Given this list of marker genes MYBPC1, MAP10, MAGI2, NDRG3 (NCBI Gene Id 64401), C2CD5, TMEM14C, TMEM263, SSMEM1, AGTRAP, AP4B1, PRKX, SQLE, AHCYL1, COPS4, NAA38, CPLANE1, MICU1, LYPD6, C5orf63, MINDY3, COX7A1, UNC5CL, C1orf141, CENPA, GAS2, FZR1, N6AMT1, ERLIN2, NAGK (N-acetylglucosamine kinase), FBF1, TUBB2B, TMEM127, SERPINA4, LYRM9, USP33, PCDH7, VPS13C (vacuolar protein sorting 13 homolog C), HS3ST6, NUP62, NOXO1, DNAJB1, GMFB, ZNF8, GNG7, TRIP4, ATP6V1C2, SOCS4, WRNIP1, ADH4, PLA2G10, NAT9, ATRN, RB1, ORAI3, NUP50, KRTAP11-1, CENPK (centromere protein K), CCDC183, FGF2, NEK3, FGD5, BRI3, CHD6, PRDM8, GALK1, TMED5, RNF145, YPEL1, ZNF777, EFCAB6, LRRC3B, TRAPPC6B, TBC1D22A, SEMA3C, TMEM269, OGFOD2, FIBP (NCBI Gene Id 9158), TNS1, REC114, TLNRD1, FITM2, WASHC1, HOXA13, METTL14, DCPS, PRKAG2, THG1L, TMEM43, ALDH18A1, TUBA1A, FBXO4, SENP8, LZTS2, ALG10, DCUN1D4, WDTC1, IGDCC4, EPHX4, KDELR3, ELFN2, MARCHF3, HTRA1, ISLR, ABAT, KCNH5, FOXQ1, PHF20, DUS3L, FAM228A, KNOP1, SLC25A15, FXR2, GSS, ZBTB42, CYB561D1, LAMTOR5, B3GALNT1, RAB25, CTTNBP2, QSOX1, TFPT, OCSTAMP, BRD10 (NCBI Gene Id 158358), ATXN1L, SPCS2, TST, SRR, SH2D4B, SIPA1L3, N4BP2, PLEKHM1, SUFU, ZNHIT3, IRGQ, ZRANB3, RHBDD2, HMBOX1, TP53I11, HOXB2, LEAP2, MICAL2, PAFAH2, AQP9, TCEANC2, ASS1, SECTM1, SLC6A13, SGTB, H6PD, PGAM5, FAM151A, SLC35F6, ACOT11 (NCBI Gene Id 91515), TRMT12 (NCBI Gene Id 55039), THOP1, SYCP2L, FAM89A, MED16, DDX39B, MAPDA, HECTD3, RAB11FIP2, ACER3, RRAGC, CXXC5, HMGN5, IGFBP6, NCAPG2 (non-SMC condensin II complex subunit G2), RNF40, DENND2C (NCBI Gene Id 163259), SLITRK4, KMO, HINT3, HTRA4, PACS2, RAD17, UBA6, ABHD15, CXCL14, CA9, PDE2A, LIPA, TMEM116, ZNF112, NKAPL, PHLDA3, KLHL22, STK40, CHST10, RAD52, APEX2 (NCBI Gene Id 27301), SLCO4C1, GK, MRPS24, ICE1, CABYR, MPDZ, PPM1F, TMEM181, here is a description of the gene set: Human Gene Set: GSE11961_PLASMA_CELL_DAY7_VS_GERMINAL_CENTER_BCELL_DAY40_DN To obtain insight into the genetic basis of the increase of functional activity of memory B cells over time, we compared the gene expression profiles of day 7 and day 40 NP-specific/IgG1 memory B cells, GC B cells and plasma cells in immunized WT mice and naïve B cells, before and after activation in vitro. Genes down-regulated in day 7 plasma cells versus day 40 germinal center B cells. species: Homo sapiens from publication Kaji T, Ishige A, Hikida M, Taka J, Hijikata A, Kubo M, Nagashima T, Takahashi Y, Kurosaki T, Okada M, Ohara O, Rajewsky K, Takemori T (PMID 23027924)